Given this list of marker genes SLC17A9, MYC, SLC6A19, PDK1, CHST15 (carbohydrate sulfotransferase 15), LDLRAP1, ZEB1, CNGA1, CXXC5, GRAMD1A, SSBP2, TNRC6C, EML5, SPACA1, CUX1, SH3BP5, SCML4 (Scm polycomb group protein like 4), ST8SIA1, FOXK1, UTP25, BACH2 (BTB domain and CNC homolog 2), TCF7 (transcription factor 7), ZNRF1, IL6ST, LRRC1, FAM78A, ACVR2A, IGFLR1, IFT80, DCAF6, USP28, ABCA1, AFP, RAB3IP, OVGP1, MIGA1 (mitoguardin 1), MIR20A, N4BP2, TDRKH, IZUMO1R, WLS, ID3, ACTN1 (actinin alpha 1), ARHGAP15, MDN1, NSG2, SLC49A4, RNF144A, GRIA3, CD2AP, RNF38, ANGPTL1, CCR9, GTF2I, CCR7 (C-C motif chemokine receptor 7), ALS2CL, IFNGR2, RAMP1 (NCBI Gene Id 10267), CRLF3, POLI, IKBKE, SLC43A2, QSER1, FOXP1, RAPGEF4, POLR1G, TOM1L2, AMPD1, SH3PXD2A, METTL9, RNF32, RAPGEF6, PPCDC, TCF20, ARHGAP5, SELE, ITGAE, FOXO1, RNF122, DNTT, RAI1, LDHB, SI, TRAT1, SFMBT2, TET1, TTC28, MAP3K3, ZBTB20, BEND5 (NCBI Gene Id 79656), IGFBP4, DDC, BCKDHB, ICE2, RNF167, NLK, SETD7, DPH5, BCOR, RFLNB, PATZ1, SLC16A5, DPP4, PANK4, RALGPS2, DZIP1, SLC11A2, LYRM7, USP53, DAPL1, PLEKHA1, SESN3, SESN1, SELL, CNR2, TREML2, TTC3, SLC27A6 (solute carrier family 27 member 6), INSR, SCMH1, ADGRG5, IL6R, TGFBR3, CYTH3, RAVER2, HDAC4, PATJ, SLC12A7, ZC3H12B, PLEKHO1, TLR1, RGS10, CEP68 (centrosomal protein 68), PLCB2, STAMBPL1, PRRG1, USP24, SLC25A27, MAP4K5, ACTN2, NEDD4L (NEDD4 like E3 ubiquitin protein ligase), IGF1R, CRIPTO, LEF1 (lymphoid enhancer binding factor 1), LRP6, HDAC7, SMAD1, FAM169BP, APPL2, KLHDC1, IL27RA, NPFF, MTSS1, TANC1, PRMT3, ADCY6, ST6GAL1, CNN3, XKRX, FXYD4, CEP97, HSPBAP1, LRIG1, FNTB, SNHG1, METTL8, here is a description of the gene set: Human Gene Set: GSE15330_LYMPHOID_MULTIPOTENT_VS_MEGAKARYOCYTE_ERYTHROID_PROGENITOR_IKAROS_KO_UP from publication Ng SY, Yoshida T, Zhang J, Georgopoulos K (PMID 19345118) species: Homo sapiens Genes up-regulated in IKZF1 knockout: lymphoid-primed multipotent progenitors versus megakaryo-erythrocyte progenitors. Regulation of lineage potential and transcriptional priming by Ikaros. New insight is provided into a bivalent regulation of lineage priming in the HSC and its lympho-myeloid restricted progeny the LMPP by the lymphoid lineage-determining factor Ikaros Whereas Ikaros is responsible for the activation of a cascade of lymphoid expression programs and for the establishment of lymphoid potential from the HSC to the LMPP it is also responsible for the repression of stem cell and erythroid genetic programs that are incompatible with further lineage restrictions emanating from the LMPP